The following is a description of a gene set: Reactome Pathway: Listeria monocytogenes entry into host cells Listeria monocytogenes is a short, gram-positive, nonspore-forming motile rod. Serotypes 1/2a, 1/2b and 4b make up more than 95% of isolates from humans, with serotype 4b causing most of the food-borne outbreaks. Listeria monocytogenes enters the body through the gastrointestinal tract after ingestion of contaminated food. The bacteria can survive food preservation procedures, such as refrigeration, low pH and high salt.<br>Listeria monocytogenes expresses several adhesin proteins at the cell surface that facilitate bacterial binding and entry to host cells. The bacteria can enter host cells through endocytosis mediated by binding of the bacterial InlA (internalin) protein to CDH1 (E-cadherin) at the host cell plasma membrane. Listeria monocytogenes can also enter host cells through endocytosis mediated by binding of the bacterial InlB protein to MET receptor tyrosine kinase at the host cell plasma membrane. Listeria monocytogenes proliferates inside the host cells and triggers formation of filopods, elongated protrusions of the host plasma membrane that contain bacteria. Filopods are ingested by adjacent cells, allowing Listeria monocytogenes to spread from cell to cell, invisible to the immune system of the host.<br>Listeria monocytogenes can cross the intestinal, blood-brain and placental barriers. In immunocompetent adults Listeria monocytogenes infection usually causes gastroenteritis. In infants infected in utero and in immunocompromised adults Listeria monocytogenes infection can result in meningoencephalitis and bacteremia (sepsis).<br>InlA is critical for crossing the intestinal barrier while both InlA and InlB are needed for crossing the placental barrier and, based on in vitro studies, the blood-cerebrospinal fluid barrier. It seems that the intrinsic level of PI3K activity in Listeria-targeted host cells determines whether the entry depends on InlA only or InlA and InlB. The interaction of InlA with E-cadherin does not activate PI3K/AKT signaling while the interaction of InlB with the MET receptor activated the PI3K/AKT signal transduction cascade. Therefore, InlB-MET interaction may be important in tissues with low intrinsic PI3K activity. Even if InlA-E-cadherin route is sufficient for bacterial entry, InlB may accelerate bacterial invasion. Cholesterol levels in host cell plasma membrane may also influence the preferred route for bacterial endocytosis. In addition to InlA and InlB, many other virulence factors are involved in the Listeria monocytogenes infection cycle and will be annotated as mechanistic details become available.<br>For review, please refer to Bonazzi et al. 2009, Brooks et al. 2010, Camejo et al. 2011, Pizarro-Cerda et al. 2012. studied in species Homo sapiens part of: Bacterial Infection Pathways, and this is the list of marker genes: GRB2, SRC, CTNND1, inlA, EPS15, HGS, SH3GL1, CBL, inlB, UBB, CBLL1, RPS27A, SH3GL3, UBA52, CTNNB1, CDH1, SH3KBP1, SH3GL2, STAM2, UBC, MET, STAM